The following is a description of a gene set: Human Gene Set: DLX4_TARGET_GENES from publication Yevshin I, Sharipov R, Kolmykov S, Kondrakhin Y, Kolpakov F (PMID 30445619) Genes containing one or more binding sites for (DLX4) in their promoter regions (TSS -1000,+100 bp) as identified by GTRD version 20.06 ChIP-seq harmonization. species: Homo sapiens, and this is the list of marker genes: PEX13, SRSF1, MRS2, PIWIL2, ZNF181, HNMT, ZNF106, FAM227B, VPS4B, WDR53, SOX2-OT, TMEM248, PADI4, C2orf49-DT, PPRC1, FAM149B1, LAPTM4A, RPL9, NIF3L1, KNTC1, ERAL1, CDK5RAP1, THADA, ZNF425, RPS26, MYL12B, WDR5B-DT (NCBI Gene Id 102723582), NGDN, ZNF408, H3C6, ZNF217, TSPAN8 (NCBI Gene Id 7103), GPATCH3, LIX1L-AS1, TSFM, USP54, BNIP1, MPHOSPH10, MRPL35, OXA1L, PPIL3, EXO1, SLC25A36, SMIM31, KCTD16, FAM187A, MRPL48, FAU, HINT3, PIH1D2, DEPDC1-AS1, SDHD, HPS5, SLC4A1AP, PNISR, DDX21, TUBD1, TFB2M, TMEM39A, ERH, TOP3A, DSG1-AS1, GOLGA3, ALKBH2, TIMM8B, KCTD10, LINC00992, PDE12, VPS33A, MRPL13, PSMB3, SH2B1, COX16, MTMR9, ZC3H10, DNMBP, WDR5B, IFRD1, GCDH, MCEE, MAP4K1, FAM222B, NUBPL-DT, RPS9, CWC25, EMC3, RUFY3, CELSR2, ACAD9, IDH3B-DT, UBE4A (NCBI Gene Id 9354), HAUS6, OAS1, RRP15, ENDOV, MED24, CDK12, SEM1, MAPDA, KRIT1, TDG, PPP1R37, LCMT1-AS1, SMARCAD1-DT (NCBI Gene Id 101929210), RPS13, PPIG, C2CD2L, SENP1, CDKL3, DDIAS, ALKBH3, CCDC77, POLDIP2, WDR36, GRWD1, ING4, DTWD1, ARL4A, DNAJA3, ACAD11, GBA1, CASP8, ZNF79, MCCC2, CD70, ZMAT2, SF3B5, OGDH, POLR3A (RNA polymerase III subunit A), STOML2, RFXANK, BORCS8-MEF2B, PPIP5K2, ARFIP1, MCCC1, POC5, GPAM, FEM1A, UTP23, TFIP11-DT, ABCB8, MICOS10-NBL1, NEDD8-MDP1, ARFIP2, MIX23, HTD2, MDH1, FBXO45, DNAJC19, PNPT1, UBQLN1-AS1, RPL39P40, RPL23, GARS1, PCNP, ATP5MF-PTCD1, AAR2 (NCBI Gene Id 51609), SEC61B, H4C2, IL23A, MED19, ARMC1, RHOC, MAU2, GPN3, ABCE1, DNAJB4, TPP1 (NCBI Gene Id 727719), DNAJC16, TMF1, SUCO, TEX14, SUGT1, RBM15-AS1, PMS2P3, RNF145, ATP5PB, ZNF213, ASB7, KBTBD4, DPH3, GUF1, UBA5, VPS33B, TTC1, COQ4, CDK13, RPL6, TMEM41B, ERAP2, NOL6, ADGRF3, SCRN3, PHF5A, CDK11A, CWF19L1, FNDC3A, SCYL3, ARID3B, TBCK, MAN2C1, EPS8, C19orf53, CCDC191, RBM8A, GPNMB, TOMM7, ZSCAN21, NUTM1 (NUT midline carcinoma family member 1), NUBP2, TMEM94, CCAR2, TMEM208, LCMT2, ATP5MG, MIR4727, RNU5D-1, RAD51C, ZRANB2-DT, CCDC97, HAX1, GIPC2, EXOSC5, SART1, MTMR4, TTI1 (TELO2 interacting protein 1), H2BC9, MRPL11, NDUFB6, ANAPC10, YLPM1, POLR1HASP, RNF111, NXT2, FANCM, ANKIB1, IFTAP (NCBI Gene Id 119710), CCDC163, PEAK1, H2AC15 (NCBI Gene Id 8330, H2A clustered histone 15), HBP1, APTX, TAX1BP1-AS1, ZNF687, METTL8, SELENOH, GTF3C3, TBC1D15, H4C16, ZNF384, SYF2, DARS2, BANF1, CETN3, RPLP1, SNORD95, H2BC15, POLR3F, SHISA5, FKBP15, HMG20A, H2AC12, CENPL, FASTKD2, ZNF131, RPS6KB1, QPCTL (NCBI Gene Id 54814), CLCN3 (NCBI Gene Id 133073), PAIP2B, NSUN6, EIF3K, MFAP1, RAB2B, GTSE1, DDX23, TIMM22, SLC27A5, GIRGL, GTF2E1, CDKAL1, BMS1P4, TTC23, AP3S2, MTFR2, LINS1, SMU1, FERMT2, DNAJC2, CEP162, SLC35A5, PUS10, EFCAB14, SNORD13, UBQLN1, FNTB, CCDC47, PSME2P3, NUP205, CAMK2D, MRPS22, ELOC, PHB1, SPINK5, EFTUD2, NKAPD1, RBM19, ACOT8, NFX1, GMPR2, HOXA-AS3 (HOXA cluster antisense RNA 3), SUPT6H, MAPK6, OXNAD1, DDX41, ZNRD2-DT, GLOD4, MAP3K7, NAGK, RSRC1, HS2ST1, OS9, SNORD18A, ZNF169, PPP2CA, MACC1, MRPL30, XRCC5, FARSB, CFAP410, VMP1 (vacuole membrane protein 1), SNORA21, ZNF12, PSMC2, UBN2, LINC00543, ZBTB37, C9orf43, ZDHHC6, DLD (dihydrolipoamide dehydrogenase, NCBI Gene Id 2654), USP3, PANK3, DPM1, SLC39A9, ACO2, UQCC6 (NCBI Gene Id 732143), AKAP13, H2BC11, AAAS, LIN7C, TRAF3IP2-AS1, ARL14, ADAP2, FNBP1P1, NUFIP1, GRN, PCNX3, GTF2F2, MED7, RPS27L, ING3, STX19, CASP9, MSL2, CENPK, CLDN12, AASS, POLQ, RALGAPB, BPGM, SMCR8, EIF3H, GGA1, ZNF770, ZRANB2, MMACHC, SF3B6, WDR83OS, LRRC28, SEC23B, PSME3, LINC01954, MITD1, RNU5A-1 (NCBI Gene Id 26833), TEFM, TMEM183A (NCBI Gene Id 92703), WRAP53, SNORD16, PFKM, PPOX, YJU2, LINC01623, PURB, HINT1, FTSJ3, WDR55, BLOC1S1, PNO1, NHP2, NDUFAF2, MICOS10-DT, TMEM242 (NCBI Gene Id 729515), DZANK1, DDX19A, EFCAB7, SEMA5A, SCAMP3, MTBP, DCAF17, MEIS2, BCAS2, RPIA, TMEM199, TLE4, ZSWIM3, DNAJB11, FBXO38, H2BC13, GAS5, PCDH12, LINC02889, COPS4, CCDC103 (coiled-coil domain containing 103), PIP5K1B, TBP (NCBI Gene Id 6908), TUT1, KRR1, PSMC5, ELL3, ETF1, MRM3, WDR83, GPBP1 (NCBI Gene Id 65056), ATG14, MTOR, SPSB3, LAPTM4A-DT, GBF1, PSMB2, FEZ2, ENSG00000187951, ACP2, SDR39U1, EIF1AD, COX7A2, SRSF11, DRAIC, ALG2, MIR3661, ITGA7, EDEM2, HOXA-AS2, SDF2, UBE3B, LGALSL, DNTTIP2, RBM25 (RNA binding motif protein 25), CEP120, RTEL1-TNFRSF6B, MRPL49, HNRNPH1, POLE3 (NCBI Gene Id 54107), ZNF830, MIR22HG, H2AC17, CDK17, LNP1, H3C7, VPS33B-DT, NDUFA4, TMEM242-DT, RACK1, GAR1, ALDH1A2, PUM3, LINC02253, GAR1-DT, NAGPA, SNAP23, NOL8, MICOS10, VTA1, FKBP3, NEDD8, ALG1, RAD51AP1, STAM-DT, BMS1P4-AGAP5, ZNF581, C1orf21, BLZF1, SKIC8, FTX, CIDECP1, NUP155, GOLGB1, FBXO8, XPNPEP1, MEF2C, EMC3-AS1, NDUFS3, QTRT2, GLYCTK, PIGT, NAIF1, TP53, POLR1H, LCMT1, DPH6-DT, FAM98B, ARSK, ARHGAP1, RPL7L1, SHOC2, SMARCAD1, SELENOI, FBXO38-DT, ARL1, RNU5E-1, GLUD1P3, BBIP1, VARS2, PIK3C3, ENSG00000249236, PRCP, GTF3C5, BCAR3, RBM22, TBRG4, FUBP1, AFG2A, POC1B, IFT56, LSM8, USP53, TAF2 (TATA-box binding protein associated factor 2), ENSG00000237773, NUBPL, NR1H3, GPALPP1, SAMTOR, XPO6, RPL14, NDUFB3, PPWD1 (NCBI Gene Id 23398), OXA1L-DT, WDR82, ELF1 (E74 like ETS transcription factor 1), COPS5, BNIP2, STMN3, GORAB, PDE4D, TFIP11, ZNF580, NSRP1 (nuclear speckle splicing regulatory protein 1), KDM5A, SLC50A1, NOP10, NFYC, GTPBP8, HYCC2, GCNT3 (glucosaminyl (N-acetyl) transferase 3, mucin type), REEP4, SH2D3A, ZNF271P, NUDCD3 (NudC domain containing 3), CCT6B, NCOA7, PACSIN2, TICRR, HEG1, TOX4, CREB3L2-AS1, HIBCH, WDR77, BUB1B, SLC25A11, TPRKB, PSMB1, SNRNP27, FGF7, SDCCAG8, PAN2, ARHGAP32, GTF2H4, IDH3B, METTL3 (NCBI Gene Id 95719), GTPBP3, FERRY3, MRPS31P4, CHCHD2, ETV6, ESYT1, NCAPD2, HIBADH, TRMO, AHCYL2, SRP54, FCRL4, UNC5B-AS1, UFC1, YAE1, SKIC3, MRPS35 (mitochondrial ribosomal protein S35), TIGD4, CNST, ILF2, TBCCD1, TMX2, RBM28, C4orf19, ZNF19, MTRF1, TMIGD1, EMC4 (ER membrane protein complex subunit 4), RNF167, PFAS, WDR89, RIMOC1, SLC25A25, SUPT7L, ZNF213-AS1, TRIM4 (tripartite motif containing 4), ATP5MF, RSRC2, CYP4F12, GTF2IRD1P1, ZNRD2, LAMA3, DDX5, EHHADH, SUN1, CIR1, UQCC1, TOMM40 (NCBI Gene Id 10452), FCF1P7, H1-2, C2orf49, UBC (NCBI Gene Id 7316), CDC14B, GAPDHP25, GIN1, CENPP, SRP54-AS1, ERCC5, EXD1, COMMD4, ATG3, MRPL46, TIMM10B, HAVCR2, EXOSC9, RPTOR, MANCR, PFDN6, MRPS11, UTP3, ZDHHC5, RBBP5, LINC02100, ECD, FAM228B, TOB1, SLC35B1, FAM135A, PPHLN1, GORAB-AS1, GTF2H1, DHX29, COMMD3, PET100, TMEM267, CLP1, KTI12, GET3, SLC31A1, SEC22B, XPO1, EMG1, HDAC6, ZC3HC1, AIRIM, LEO1, ZSCAN30, TRIM5, NME7, RECQL5, XAB2, CACTIN (cactin, spliceosome C complex subunit), CLASP1, CHASERR, BCKDHA, TTC32-DT, SLC30A4-AS1, SNRPB, DNAAF10, NSA2, RN7SKP192, C12orf76, VASP, RTEL1, ZZZ3, EIF3F, DPAGT1, NUDT6, CEP44, GFM2, POLB, RNU7-27P, WDR46, SELENOF, LIN52, POLR3B, NEK2-DT, IPO11, NOL11, GTSE1-DT, PHB2 (prohibitin 2), ZNF17, TRUB2, TRMT12, RPP14, TAF6L, HAUS2, YARS2, ITGB3BP, DMTF1, MRPS31P5, SUPV3L1, HMGN2P46, MAGOHB, CNOT1, TRMT1, RAB3GAP1, CWF19L2, AARS2, SERPINI1, H3C12, TPM1-AS, MAP3K11, TACO1, MPDU1-AS1, ERCC8, ELP3, RBM15, GEMIN2, ZFYVE26, DDX42, CCT8, NIFK-AS1, MGC32805, CLPTM1, POC1B-GALNT4, SEC24A, TRMT10C, KNL1 (NCBI Gene Id 57082), DENND4A, BABAM1, BRF2, ICE2, ANKRD17, TTC32, PTRH2, SNHG21, HACL1, PRR3, EED, STAM, CMSS1, FBXL9P, SMG8, PRR13P5 (NCBI Gene Id 651143), ACTR6, PSMB7, SELENOP, FUZ, IWS1, NUCKS1, H2BC5, RBFOX2 (RNA binding fox-1 homolog 2), ATG4C, CORO7, ZCRB1, H2BC17, PCM1, CSPP1, RN7SL346P, DHX16, MRPL51, FANCD2, CLTC, AIMP1, KCTD5, NOSTRIN, YIPF5, ZNF165, REV3L, SEMA3C, DDX19B, PFDN1, CAB39L, UQCC4, BET1, MDH1B, AGR2, NUP42, ENSG00000255647, GTPBP10, VTI1A, BORCS8, CHP1, DMXL2, ATAD2B, PPP1R11, ZW10, BYSL, ARIH1, MED20, RPRD1B, TM4SF4, ARMC8, FAM216A (family with sequence similarity 216 member A), COG5, RPL41, PTCD1, SH3RF2, CDH17, DHDDS, LRRC40, AHR, MAP3K13, VCPIP1, TBL1XR1, CLDN7, HELQ, H4C5, SAP30BP, GNL1 (G protein nucleolar 1 (putative)), MRPS18C, PARK7, WDPCP, MUL1, SNRPD2, DMAC2, C5orf24, RABL3, ARHGAP11B-DT, LIAS, DDX19A-DT, NEK2, MOCS3, TMEM70, CSNK1G1, PDCD10, LRRC57, KCNK1, TTI2, SUGP1, GPI, RNF213-AS1, TARS2, SRI, ALDH6A1, COPS7A